Given this list of marker genes Ctss, Gga2, Myl12b (myosin, light chain 12B, regulatory), Gpr65, Lims1, Sema4d, Ero1b, Tmem50b, Gmip, Lyn, Pip4k2a, Ptprc, Ptpn6, Slc25a53, Il10ra, Selenow, Ly6d, Lat2, Scd1, Atp6v0b, Ifi30, Cd74, Smap2, Pml, Gns, Capn1, Dtx1, Birc3, Dusp6, Ms4a1, Cd83, Gucd1, Mcl1, Igkv17-127, Adcy7, Cd72, Pxk, Traf3, Neat1 (NCBI Gene Id 66961), Jarid2, Samhd1, Hck, Rgl2, Rgs14, Capg, Rhoq, H2-DMa, Gpcpd1, H2-DMb1, Cnr2, Btg1, Igkv14-111, here is a description of the gene set: Up-regulated genes in the B lymphocyte developmental signature based on expression profiling of lymphomas from the Emu-myc transgenic mice: the immature B stage. from publication Mori S, Rempel RE, Chang JT, Yao G, Lagoo AS, Potti A, Bild A, Nevins JR (PMID 18922927) The Emu-myc transgenic mouse has provided a valuable model for the study of B-cell lymphoma. Making use of gene expression analysis and, in particular, expression signatures of cell signaling pathway activation, we now show that several forms of B lymphoma can be identified in the Emu-myc mice associated with time of tumor onset. Furthermore, one form of Emu-myc tumor with pre-B character is shown to resemble human Burkitt lymphoma, whereas others exhibit more differentiated B-cell characteristics and show similarity with human diffuse large B-cell lymphoma in the pattern of gene expression, as well as oncogenic pathway activation. Importantly, we show that signatures of oncogenic pathway activity provide further dissection of the spectrum of diffuse large B-cell lymphoma, identifying a subset of patients who have very poor prognosis and could benefit from more aggressive or novel therapeutic strategies. Taken together, these studies provide insight into the complexity of the oncogenic process and a novel strategy for dissecting the heterogeneity of B lymphoma. Mouse Gene Set: MORI_IMMATURE_B_LYMPHOCYTE_UP species: Mus musculus